Given this list of marker genes Mthfd2, Mthfr, Slc19a1, Slc25a32, Folr2, here is a description of the gene set: part of: Metabolism of water-soluble vitamins and cofactors This event has been computationally inferred from an event that has been demonstrated in another species.<p>The inference is based on the homology mapping from PANTHER. Briefly, reactions for which all involved PhysicalEntities (in input, output and catalyst) have a mapped orthologue/paralogue (for complexes at least 75% of components must have a mapping) are inferred to the other species. Reactome Pathway: Metabolism of folate and pterines electronically inferred by orthology from the curated human pathway studied in species Mus musculus